Given this list of marker genes Kxd1, Hps6, Dtnbp1, Snapin (NCBI Gene Id 99847), Snap25, Washc1, Pi4k2a, Bloc1s3, Bloc1s5, Bloc1s4, Bloc1s2, Bloc1s6, Hps5, Hps1, Hps3 (NCBI Gene Id 12807), Bloc1s1, Washc4, Stx12, Snap47, Hps4, here is a description of the gene set: species: Mus musculus Any of several protein complexes required for the biogenesis of specialized organelles of the endosomal-lysosomal system, such as melanosomes, platelet dense granules, and other related organelles; acronym for biogenesis of lysosomal-related organelles complex. Mouse Gene Set: GOCC_BLOC_COMPLEX